The following is a description of a gene set: Kaposi's sarcoma (KS) is the most frequent AIDS-associated malignancy, etiologically linked to the infection with the human herpesvirus 8 (HHV-8/KSHV). This member of the gamma-herpesviridae family encodes 81 open reading frames, several bearing oncogenic potential. A constitutively active virally encoded G protein-coupled receptor (vGPCR) readily induces KS-like lesions when expressed in endothelial cells in vivo, and unmasks the oncogenic potential of other HHV-genes in a paracrine fashion. How vGPCR causes endothelial cell transformation is still not fully understood. Using full-genome microarray analysis we show here that the expression of nuclear factor-kappaB (NF-kappaB)-regulated genes is a prominent feature triggered by vGPCR in cells expressing this viral oncogene and in cells exposed to vGPCR-induced secretions, thus mimicking its paracrine effect. Indeed, vGPCR activates the NF-kappaB pathway potently, and NF-kappaB activation is a hallmark of both human and experimental KS. Of interest, whereas constitutive NF-kappaB signaling is not sufficient to promote endothelial cells transformation, NF-kappaB function is strictly required for vGPCR-induced direct and paracrine neoplasia. Taken together, these results strongly support the role of NF-kappaB regulated genes in KS pathogenesis, thus providing the rationale for the development of novel mechanism-based therapies for this angioproliferative disease. Mouse Gene Set: MARTIN_NFKB_TARGETS_UP NF-kB-controlled genes up-regulated in endothelial cells in response to viral GPCR protein. species: Mus musculus from publication Martin D, Galisteo R, Ji Y, Montaner S, Gutkind JS (PMID 17934524), and this is the list of marker genes: Trim2, Car2, Ccl7, Cdc14b, Igfbp7 (NCBI Gene Id 29817), C1s1, Flt1, Dusp6, Osmr, Pld4, Lats2, Fsd1, Zcwpw1, Gtf3c1, Trpv6, Syn3, Bcl2, Inhbb, Myc, Mtrf1, Cp, Vegfa, Atp8a2 (NCBI Gene Id 50769), Opn4, Nfkbiz, Il10, Ppp1r1b, Klra13-ps, Bicdl1, Ttyh3, Slc26a9, Cxcl12, Spp1, C3, Ccl2, Slc29a1, Prkce, Vcam1, Slc16a4, Cxcl9 (NCBI Gene Id 17329), Casp4, Abcb1b, Saa1, Cxcl1, Steap4 (STEAP family member 4)